Given this list of marker genes DTWD1, HEY2, PSMA1, RUBCN, PUS1, TESMIN, BHLHE40 (NCBI Gene Id 8553), DCXR, RPS2, PHAF1, DPEP3, FIRRM, EIF2B2, H4C13, DFFB, JAK3, NUDT4, CRYAB (crystallin alpha B), ZNF394, SPPL2B, LINC00652, RRP15, PPEF2, EFL1, RET, EHF, MATN1, KLHL26, CLDN4, DGKB, MYBL2, IKZF2, CYP2B6 (NCBI Gene Id 82059), KIZ, PTCD3, ULK2, REG1CP, MAP4, G6PC1, MTMR8, CLUAP1, TMEM120B, LPL, MRC1, TBC1D16, RECK, IGHG1, KLK2, UBA7 (ubiquitin like modifier activating enzyme 7), SDHD, VASH2, ANKS1B, PPIL2, CDR2L, CPS1, HSD17B1, UNC5C, CRISP3, UCK2, BHMT2, WDR13, LHFPL6, LRP1B, RP2, CLMN, SPATA7, KCTD3, BAHCC1, IL12RB1, GNAO1, BORCS6, ATXN7L1, ZNHIT1, SRGAP2, CTNNAL1 (catenin alpha like 1), GAD2 (glutamate decarboxylase 2), MAGEC3 (NCBI Gene Id 442793), ENSG00000274253, FBXO11, SPCS1, APOC1, SMIM27, ADGRL4 (adhesion G protein-coupled receptor L4), MACROD1, SOX30, POLR2D, INSM1, STAB1, MAGEA6, RADX, FBP1, TTC9, OSTF1, IFT25 (intraflagellar transport 25), CLSPN, ROCK2, P2RX3, SAP30L-AS1, SPTLC1, CLSTN3, PPM1E, SOX2 (SRY-box transcription factor 2), LTN1, ESR1, STAG3, MAP2, BPI, CLC, DDX1, LGALS3BP, YWHAZ, IL20RA, CBR1, FZD2, WDCP, MT4, PEX5L, CSRNP3, PSD3, DRC3, SI (sucrase-isomaltase), TNS3, MACROH2A1, BHLHE41, H4C2, CDK12, TUBA1A, LPCAT4, CORO1B, UNC50, FUCA1, DPPA4, ADGRF5, CRIP1, FBLN5, REXO5, ZHX3, SORCS3, OAZ3 (ornithine decarboxylase antizyme 3), CNTLN, ALDOAP2, HSPG2, MED14, NPAS3, SLC18A1, EPB41L1, NME3, BRIP1, MRPS35, MUC7 (NCBI Gene Id 93297), SCT, GRTP1, COL8A1, BCL2L11, GSDMB, WRNIP1, RAB22A, CCL24, ALX4, CIRBP, ST3GAL6, OGFOD2, GNRH2, AKR1C3, TNNI2, CTDSP2, GCG, F10, MORC1 (NCBI Gene Id 27136), SKIC2, GNAI2, NMBR (NCBI Gene Id 4829), MRM3, TRIM46, SULT1E1, TRPC1 (NCBI Gene Id 7220, transient receptor potential cation channel subfamily C member 1), ARG2, CLCA3P (chloride channel accessory 3, pseudogene), CEP295, UBL3, PDK4, SLC30A4, XPA, SLC22A6, DTYMK, PLD3, SOX10, ADAM2, FAM3A, ADA2, DNAJC12, NRIP2, SSRP1, SOCS7, GPNMB, GPM6A, here is a description of the gene set: NOD2 is an intracellular receptor for the bacterial cell wall component muramyl dipeptide (MDP) and variants of NOD2 are associated with chronic inflammatory diseases of barrier organs e.g. Crohn disease, asthma and atopic eczema. It is known that activation of NOD2 induces a variety of inflammatory and antibacterial factors. The exact transcriptomal signatures that define the cellular programs downstream of NOD2 activation and the influence of the Crohn-associated variant L1007fsinsC are yet to be defined. To describe the MDP-induced activation program, we analyzed the transcriptomal reactions of isogenic HEK293 cells expressing NOD2wt or NOD2L1007fsinsC to stimulation with MDP. Importantly, a clear loss-of-function could be observed in the cells carrying the Crohn-associated variant L1007fsinsC, while the NOD2wt cells showed differential regulation of growth factors, chemokines and several antagonists of NF-κB, e.g. TNFAIP3 (A20) and IER3. Human Gene Set: GSE22611_MUTANT_NOD2_VS_CTRL_TRANSDUCED_HEK293T_CELL_DN from publication Billmann-Born S, Till A, Arlt A, Lipinski S, Sina C, Latiano A, Annese V, Häsler R, Kerick M, Manke T, Seegert D, Hanidu A, Schäfer H, van Heel D, Li J, Schreiber S, Rosenstiel P (PMID 21335489) Genes down-regulated in HEK293 cells: expressing mutant NOD2 versus control. species: Homo sapiens